The following is a description of a gene set: Genes down-regulated in CD34+ cells: control versus treated with GSK-3 Inhibitor IX (BIO). from publication Trompouki E, Bowman TV, Lawton LN, Fan ZP, Wu DC, DiBiase A, Martin CS, Cech JN, Sessa AK, Leblanc JL, Li P, Durand EM, Mosimann C, Heffner GC, Daley GQ, Paulson RF, Young RA, Zon LI (PMID 22036566) Human Gene Set: GSE26351_UNSTIM_VS_WNT_PATHWAY_STIM_HEMATOPOIETIC_PROGENITORS_DN species: Homo sapiens Analysis of mobilized peripheral blood CD34+ cells from a healthy volunteer under erythroid differentiation conditions with and without stimulation to the BMP or Wnt signaling pathways. For erythroid differentiation, expanded CD34+ cells were placed in Stemspan SFEM medium supplemented with 2% pen/strep, 20ng/ml SCF, 1U/ml Epo, 5ng/ml IL3, 2uM dexamethasone, and 1uM beta-estradiol. Arrays were performed 2 hours after addition of cytokines. For signaling pathway stimulation, cells were exposed to 0.5uM BIO (a GSK3 inhibitor) for Wnt pathway activation, 25ng/ml rhBMP4 for BMP pathway activation, or vehicle control for 2 hours. Three biological replicates were performed per treatment group. We used microarrays to detail the global program of gene expression changes after Wnt or BMP pathway stimulation in human CD34+ hematopoietic progenitors under erythroid differentiation conditions., and this is the list of marker genes: ALDH7A1, AGPS, POF1B, TMEM208, ABTB1, STBD1, SRC, YIF1B, MAP4K4, ID1, CMYA5, PIK3R4, ELP3, TSACC, MYL2, RNF115, SLC23A2, SEC62, WDR35, PEX6, RNF169 (ring finger protein 169), ZNF106, ZNF330, SPTBN1, SIL1, ECH1, EFNB2, HSPB1, SMPD2, EPRS1, BCKDHB, PORCN, EDN1, ETF1, SH3BP5L, RBMXL1, VPS9D1, TRPV2, TTLL11 (NCBI Gene Id 401550), DDX31, RALBP1, HEATR5A, VPS54, ORMDL2, TMEM209, B4GALT1, RAB8B, COPZ2, JDP2, SMAD1, RGMB (repulsive guidance molecule BMP co-receptor b), STX2, PRDX4, TMEM222, NECAP1, CR1L, PLBD2 (NCBI Gene Id 196463), ARHGEF40, OMA1, PDCL3, TRIM8, ZPR1, E4F1, PSMB6, KCTD21, WLS, SEC22A, MMUT, ARID5A, PIK3CG, PRDX5, MANBA, CCPG1, DYNLT3, TFB2M, ECI2, VDAC3, DSE, SMARCAL1, PINK1, MARCHF5, MED13, ELOA, MYDGF, SLC37A4, PEX10, CEP95, XYLB, APOE, DCAF13, POMT1, ZNF35, CHIC2, GTF3C4, ATP8A1, PEX11A, GLRX3, RAB5A, AMN1, PRDX2, RRP1B, MBTD1, MAP3K20, PHKA2, GTF2E2, TTL, NXT2, DOK3, MPHOSPH9, EVA1B, FUT11, TIFA, NKRF, CRAMP1, STEEP1, RIMOC1, GADD45A, EPC2, FOSL1, XPO7 (exportin 7), RBM33, YTHDF1, MALSU1, GMIP, INPP5A, ATF2, PLEKHA2, TEX261, BLMH, ATP7A, HMCES, ENG, GLIS3, PXDC1, GKAP1, KPNB1, EED, TMOD1, ADAM9, PHF20, FBXL20 (F-box and leucine rich repeat protein 20), RPS19BP1, SMAD7, GDAP2, NDUFA5, GCLM, DOLK, MED29, CTDSP2, CEPT1, PFAS, RNF216, ZBTB48, C3orf62, LMF1, PIGL, ARHGAP35, PCMTD1, ABHD5, KIFBP, TMEM135, MNT, TMEM18, RGCC, FAM3C, UBR1, RUVBL1, HGSNAT, MMGT1, PTPRA, ASAH2, WBP1L, PAIP2, CPQ, KLHL24, VPS41, GSDMD, MCRIP2, PDCD2L, BCR, FYTTD1, NFYC, CHMP7, BAMBI, CSE1L (NCBI Gene Id 1434), PCMT1, MAP1LC3B, NUP42, TATDN3, SMIM14, RPUSD4, TBL2, PPP2R5E, RFX3, ST13, LARS1, UBXN4, NCOA3, CEP170, PPP2CA